Given this list of marker genes MDN1, FMNL3, DNLZ, RNF145, CRISP3 (cysteine rich secretory protein 3), LARS2, USP4, EYA1, MAP3K7, AVL9 (AVL9 cell migration associated), PDE12, TRMT10C, FEM1A, PAIP1, VCPKMT, RNF187 (NCBI Gene Id 149603), SMIM13, MCMBP, LCMT2, ISYNA1 (NCBI Gene Id 51477), SIAH2, PDIA6, KDM5A, PNPO, DONSON, TMEM31, ORMDL1, RNF13, AFG2B, CDK2, MTAP (methylthioadenosine phosphorylase), MAPRE2, PRDM15, HIBCH, ZBTB24, RPUSD4, SCAPER, LURAP1, DCUN1D4, NOA1, DCAF17, NXT2, PEX10, PITHD1, CPEB2, PCYOX1L, MLH3, MFSD14A, FAM120AOS, HUWE1, SLC35F2, NPM3, SGSM3, RUFY1, WARS2, MTFR1, ICAM2, OXR1, SH3BP5, KMT2C, NSA2 (NCBI Gene Id 10412), ARMCX4, LIPG, PCMTD2, FBXW7, GALNT4, CYFIP2, SEC24A, TMEM126B, NDUFA1 (NCBI Gene Id 4694), SMPD3, OTUD6B, RNF19A, SYNCRIP, SLC39A10, PPP2R5A, C5orf24, DCUN1D1, CTNNAL1, SNAP23, GNE, PURB, ZNF821, CDC73, RNF146, ZBTB1, RIC8A, REXO2, ZNF383, SLC39A6, AKAP9, SLC44A1 (solute carrier family 44 member 1), FITM2, SLC4A1AP, MGA, INTS6 (NCBI Gene Id 26512), RP2, GABPA, NUDCD1, EBF1, SHMT2 (NCBI Gene Id 6472), MGLL, LATS1, TBP, TMEM259, ADD3, KLF3, ZNF397, RPSA, UGCG, MIGA1, UBL3, SLC38A2, ZHX1, UBE2J1, ACADM, C1GALT1C1 (NCBI Gene Id 29071), CBL (NCBI Gene Id 867), UAP1, TNFRSF8, DDX18, CECR2, STT3A, LYSMD3, AACS, IKZF5, EFL1, FAR1, ZDHHC20, UCHL1, WDR55, TNFRSF13C, CNOT2, LMO4, AGO2 (argonaute RISC catalytic component 2), PRMT5, THAP4, HACD1, EIF3G, INTS4, MALAT1, CRYBG2, MYNN, FCRL1, MTM1, DIS3L, SNX16 (NCBI Gene Id 64089), LETMD1, AMIGO2 (adhesion molecule with Ig like domain 2), MFSD14B, NGEF, FAM78A, MRPL19, ZNF317, NETO2, TTC13, BZW2, RAD17, GAN, TUBB2B, GPAT3, ARID5B, UBE3D, PCGF6, HLX, KCTD14, NME2, NAA16, ARFIP2, UTP11, SLC22A5, RNF2, SLFN13, KBTBD7, PPP4R1, PCED1A, EML4 (NCBI Gene Id 54548), TMEM177, PDAP1, ZNF566, MAP3K10, GALK2, SLC35B1, YES1, PRDX6, WDR20, TXNDC5, FLCN, TXLNA, MBTPS1, SLC16A6, DYRK1A, CSNK1E, MBNL1, CDC37L1, SLC30A4, VKORC1L1, FCER2, GATC, WWP2, here is a description of the gene set: studied in species Homo sapiens from publication Doering TA, Crawford A, Angelosanto JM, Paley MA, Ziegler CG, Wherry EJ (PMID 23159438) Genes down-regulated in CD8 T effector cells during chronic infection with LCMV-Clone 13: day 6 versus day 8. During acute viral infections, naïve CD8+ T cells differentiate into effector CD8+ T cells and, after viral control, into memory CD8+ T cells. Memory CD8+ T cells are highly functional, proliferate rapidly upon reinfection and persist long-term without antigen. In contrast, during chronic infections, CD8+ T cells become “exhausted” and have poor effector function, express multiple inhibitory receptors, possess low proliferative capacity, and cannot persist without antigen. To compare the development of functional memory T cells with poorly functional exhausted T cells, we generated longitudinal transcriptional profiles for each. Human Gene Set: GSE41867_DAY6_VS_DAY8_LCMV_CLONE13_EFFECTOR_CD8_TCELL_DN